Given this list of marker genes ASNS, MAGED2, ABHD2, TP53RK, DBF4B, SESN2, USP22, ELP6 (NCBI Gene Id 54859), DTL, SUMO2, MIDN, TLE5, GPATCH2L, NFIL3, PEG10, DVL2, MAPRE2, BTG1, TSTD2, RBM12, DHFR, PNRC1, SGTA, PTOV1, HIF1A, SKP2, DAPK3, FBXO7, CCND1, INKA2 (inka box actin regulator 2), MUTYH, ARMC6, SOX11, GPN2, TP53, MLF2, SUMO4, IREB2, MXD1, DENND5A, KCTD3, HMGCR, SOX4, KIF1A, COMMD2, C15orf39, WEE1, EP300, here is a description of the gene set: studied in species Homo sapiens from publication Benitez JA, Finlay D, Castanza A, Parisian AD, Ma J, Longobardi C, Campos A, Vadla R, Izurieta A, Scerra G, Koga T, Long T, Chavez L, Mesirov JP, Vuori K, Furnari F (PMID 33428749) Background <BR/>Glioblastoma (GBM) is the most common primary brain tumor in adults with a median survival of approximately 15 months, therefore, more effective treatment options for GBM are required. To identify new drugs targeting glioblastomas, we performed a high throughput drug screen using patient-derived neurospheres cultured to preferentially retain their glioblastoma stem cell (GSC) phenotype. <BR/>Results<BR/>We found that GSCs were highly sensitive to proteasome inhibition due to an underlying dependency on an increased protein synthesis rate, and loss of autophagy, associated with PTEN loss and activation of the PI3K/mTOR pathway. In contrast, combinatory inhibition of autophagy and the proteasome, resulted in enhanced cytotoxicity specifically in GSCs that did express PTEN. Finally, proteasome inhibition specifically increased cell death markers in3D glioblastoma organoids, suppressed tumor growth, and increased survival of mice orthotopically engrafted with GSCs. As perturbations of the PI3K/mTOR pathway occur in nearly 50% of GBMs, these findings suggest that a significant fraction of these tumors could be vulnerable to proteasome inhibition.<BR/>Conclusions<BR/>Proteasome inhibition is a potential synthetic lethal therapeutic strategy for GBM with proteasome addiction due to a high protein synthesis rate and autophagy deficiency 102 proteins were identified that were specifically and significantly accumulated after proteasome inhibition with carfilzomibin the PTEN-KO GBM spheres compared with placebo-treated and were not statistically present in the PTEN-WT drug vs placebo group at the proteomic level, this proteomic signature was then coorelated with the RNA-level transcriptomic response to carfilzomib using GSEA. The leading edge of the enrichment result was selected as the response signature. Human Gene Set: BENITEZ_GBM_PROTEASOME_INHIBITION_RESPONSE